Given this list of marker genes Sox5, Wnt5a, Zfp219, Prkg2, Smad3, Tapt1, Hoxa11 (NCBI Gene Id 15396), Mdk, Pkdcc, Bmp6, Fgf18, Gdf6 (NCBI Gene Id 242316), Gli3, Mustn1, Bmpr1b (bone morphogenetic protein receptor, type 1B), Sox9, Gdf5, Gdf2, Bmpr2, Bmp4, Sox6, Ccn1, Runx2, Hoxd11, Zbtb16, Bmp2, Smad7, Thrb, Rela, Por, Loxl2, Scx, Smad1, Bmp10, Bmp1, here is a description of the gene set: Mouse Gene Set: GOBP_POSITIVE_REGULATION_OF_CARTILAGE_DEVELOPMENT Any process that increases the rate, frequency, or extent of cartilage development, the process whose specific outcome is the progression of the cartilage over time, from its formation to the mature structure. Cartilage is a connective tissue dominated by extracellular matrix containing collagen type II and large amounts of proteoglycan, particularly chondroitin sulfate. studied in species Mus musculus